The following is a description of a gene set: studied in species Homo sapiens Human Gene Set: HP_SOMATIC_SENSORY_DYSFUNCTION An abnormality of the primary sensation that is mediated by peripheral nerves (pain, temperature, touch, vibration, joint position). The word hypoesthesia (or hypesthesia) refers to a reduction in cutaneous sensation to a specific type of testing. Somatic sensory dysfunction, and this is the list of marker genes: GABBR2, SCN11A, DCAF8 (NCBI Gene Id 50717), SAMD9L, PI4KA, PWRN1, ATP7B (NCBI Gene Id 540), HSPD1, UBTF, CCT5, PRX, KNSTRN (NCBI Gene Id 90417), SCN10A, MT-ATP6, PGM3, GNAS, DSE, PRPS1, UBAC2, HK1 (NCBI Gene Id 59333), HNRNPK (NCBI Gene Id 3190), CYP27A1, DYSF, POLE, DHH, KCNQ1OT1, IFRD1, ATP1A2, SPTLC2, MLH1, ATXN3, TGFBR2, KPNA3, PLS1, POU4F1, TP53, COQ6, PLD3, WNK1, CALR, NEFH, RIPOR2, KRT1, ATP1A1, SLC25A19 (solute carrier family 25 member 19), EPCAM, SYNE1, JAG1, BAG3, GMPPA, LMX1B, ADSS1, SPTBN2, P4HA2, RASA1, SOX10, CAMTA1, WASHC5, SH3TC2, DARS2, SRPX2, GALC, TRIM32, JPH1, MYORG, HRAS, DNM1L, MTMR2 (NCBI Gene Id 8898), IBA57, KDM5C, RNASEH1, MEFV, AARS1, XK (NCBI Gene Id 7504), TDP1, TMEM218, AFG3L2, H19, SETX, ZEB2, STX16, ITPR1, ABCD1, SLC25A15, BSCL2, SCN9A, VPS37A, PDK3, ATXN8OS, SEPTIN9, SNUPN, HLA-DQB1, ATM, SORD, CADM3, TTR, WDR48, ADAMTS15, SAR1B, RFC1, CASR, MSTO1, TGM6, KIF1A, GPI, PSAP, TLR4, BMPR1A, YARS1, PLOD1, C19orf12, MARS1 (NCBI Gene Id 4141), TBP, HPGD, CLTCL1, HSPB1, DHTKD1, REEP2, CHP1, MAPT, SPG11, TET2, RPS20, GJB1, HLA-B, KRAS, LITAF, FAS, SLC12A6, VCP, GAN, KRT14, PIEZO2, OCA2, NR4A2, PNPT1, ERLIN2, ALAD, NTNG1, MPZ, NALCN, TYMP, ABCA1, IFNGR1, RTN2, FBN1, ATXN10, FGF14, ELOVL5, STUB1, SMC1A, OPA3, PRKCG, PEX16, COA7, GBF1, PIK3R5, MFN2, SBF1, MSH6, SLC2A1, GLA, MKRN3, KLC2, COX6A1, SLC12A3, MSH2, FBLN5, GBA2, NF2, B4GALNT1, MATR3, KRIT1, CBLIF, PMS2, CACNA2D1, CHCHD10, LRSAM1, CCM2, TRIO, UROS, NIPA1, POLR3A, GARS1, IL12A-AS1, TRPV4, HARS1, ALS2, HEXB, ITPR3, FLII, KLRC4, KLHL9, ATXN1, DYNC1H1, EXT1, MADD, SDHA, KRT9, NGF, FXN, SLC25A46, MCM3AP, FIG4, ENSG00000288330, DNAJB2, HSPB8, SNORD116-1, TTPA, PDYN, DKK1, DEAF1, ZFHX2, DEPDC5, AIFM1, POLG, AASS, POLD1, NFU1, GRIA3, MED25, NPRL3 (NCBI Gene Id 8131), CAV3, IARS2, XRCC1, COMP (cartilage oligomeric matrix protein), PHYH, SLC12A1, ABCB7, PRORP (NCBI Gene Id 9692), FLVCR1, ERAP1, UCHL1, MYH14, PRNP, NAGLU, EGR2, HLA-DRB1, MT-TE, ADCY6, PMP22, NEFL, MPL, UBAP1, PEX7, VPS41, SCN1A, LYST, MORC2, MUTYH, CDKL5 (NCBI Gene Id 6792), ERBB3, GDAP1, EBF3, ATL3 (atlastin GTPase 3), CUBN, CACNA1G, SLC33A1, AIP, PDXK, GJC2, IMPDH2, SACS, ATP7A, PLEKHG5, HAX1, REEP1, NPRL2, MME, APP, SH2B3, GNA11, PNKP, BEAN1, GABRG2, GNA14, DAB1, HTRA1, SCO2, SEMA4A, SPG7, NOTCH2NLC, SCN4A, FGD4, KRT16, ATP13A2, VPS13A, SPART, HINT1, RRM2B, HPDL, AMPD2, HERC2, PEX10, PRDX3, ZFYVE26, TK2, PMS1, CYP7B1, CHST14, PEX6, TWNK, CTDP1, SNRPN, CAPN1, RAI1, ALDH4A1, ARSI, SLCO2A1, SPTAN1, PLEKHG4, SERPING1, CLDN9, SNORD115-1, GCH1, GATA1, PRRT2, RETREG1, LMNA, HDAC4, HMBS (NCBI Gene Id 5448), KIF1B, GRIN2A, ZFTA, IQSEC2, NAGA, ALMS1, EXT2, NLRP3, DNM2, PIK3CA (NCBI Gene Id 5290), LZTR1 (leucine zipper like post translational regulator 1), AEBP1, SIM1, FMR1, SLC19A2, CLCNKB, LIG3, LMNB1, RFX7, LIFR, STAT4, THPO, NTRK1, APTX, NKX6-2, IL10, EEF2, RNF170, JAK2, MAGEL2, PMP2, IGF2, SYNGAP1, TRPM3, KIF5A, NGLY1, SYT2, TNFRSF1A, NDN, TPP1, ABHD12, UROD, SLC26A2, ATL1, SPTLC1, CHEK2, VAMP1, FLRT1, MPV17, CCR1, ADA2, VPS13D, CAV1, KRT5, ZFHX3, PIK3CD, NARS1, RAB7A, PWAR1, C4A, MTHFR (methylenetetrahydrofolate reductase), POLR3B, SPAST, DNAJC3, GBE1, CPT1C, VWA1, TGM1, PTPN22, TFG, MAG, XPA, ATXN7, ATXN2, KCNJ1, PRDM12, SERPINI1, ALDH18A1, FLI1, SCYL1 (NCBI Gene Id 57410), TRAPPC2, GPR101, BRCA2, CHAMP1, IRF2BPL, KCND3, IGHMBP2, GNB4, KCNC3, PPOX, ATP2A1, SBF2, IL23R, KARS1, SCP2, MTTP, MECP2, CCND1, ATN1, ELP1, MEN1, INF2, COL1A1, MTRFR, CSF1R (colony stimulating factor 1 receptor), CACNA1A, YY1, UNC80, NDRG1, DDHD1, PDCD10 (programmed cell death 10), IL12A, FLNC (NCBI Gene Id 2318), SMARCB1, NPAP1 (nuclear pore associated protein 1), SHANK3